The following is a description of a gene set: species: Homo sapiens Human Gene Set: GOBP_CELLULAR_RESPONSE_TO_PEPTIDOGLYCAN Any process that results in a change in state or activity of a cell (in terms of movement, secretion, enzyme production, gene expression, etc.) as a result of a peptidoglycan stimulus. Peptidoglycan is a bacterial cell wall macromolecule., and this is the list of marker genes: TREM2, RELA, IRF5, DEFB124, CAMP, NOD2, RIPK2